Given this list of marker genes SPA17, AKAP4, PGK2 (phosphoglycerate kinase 2), FSCB, LDHA (NCBI Gene Id 3939), GSTM3, CABYR, TSGA10, AKAP3, here is a description of the gene set: A cytoskeletal structure surrounding the axoneme and outer dense fibers of the sperm flagellum. Consists of two longitudinal columns connected by closely arrayed semicircular ribs that assemble from distal to proximal throughout spermiogenesis. The fibrous sheath probably influences the degree of flexibility, plane of flagellar motion, and the shape of the flagellar beat. Human Gene Set: GOCC_SPERM_FIBROUS_SHEATH studied in species Homo sapiens